Given this list of marker genes Dnmt1, Slc1a1, Mc4r, Chek2, Dnmt3a, here is a description of the gene set: Mouse Gene Set: GOBP_RESPONSE_TO_BISPHENOL_A Any process that results in a change in state or activity of a cell or an organism (in terms of movement, secretion, enzyme production, gene expression, etc.) as a result of a bisphenol A stimulus. species: Mus musculus